The following is a description of a gene set: Comprehensive identification of all functional elements encoded in the human genome is a fundamental need in biomedical research. Here, we present a comparative analysis of the human, mouse, rat and dog genomes to create a systematic catalogue of common regulatory motifs in promoters and 3' untranslated regions (3' UTRs). The promoter analysis yields 174 candidate motifs, including most previously known transcription-factor binding sites and 105 new motifs. The 3'-UTR analysis yields 106 motifs likely to be involved in post-transcriptional regulation. Nearly one-half are associated with microRNAs (miRNAs), leading to the discovery of many new miRNA genes and their likely target genes. Our results suggest that previous estimates of the number of human miRNA genes were low, and that miRNAs regulate at least 20% of human genes. The overall results provide a systematic view of gene regulation in the human, which will be refined as additional mammalian genomes become available. Human Gene Set: MCAATNNNNNGCG_UNKNOWN Genes having at least one occurrence of the highly conserved motif M110 MCAATNNNNNGCG in the regions spanning 4 kb centered on their transcription starting sites. The motif does not match any known transcription factor binding site. from publication Xie X, Lu J, Kulbokas EJ, Golub TR, Mootha V, Lindblad-Toh K, Lander ES, Kellis M (PMID 15735639) studied in species Homo sapiens, and this is the list of marker genes: TAFA1, MAF, RNFT2 (NCBI Gene Id 84900), CNN2, CDCA3 (cell division cycle associated 3), SUV39H1, PTCHD1, SLIT3, HNRNPL, HOXB8, MSX2, AMD1, LONRF3, PAPOLG, HMGN2, OARD1, SH3GL3, NOL6, ATP2A2, POLDIP3, FBXL20, CCNT2, ADAM10, PRADC1, LIG1, VASP, CCT7, FICD, ATF2, JUP, HES1, RAD51C, RMI2, NFYA, NIM1K, ABI1, SPRING1 (NCBI Gene Id 79794), CNNM2, SH3BGRL3 (SH3 domain binding glutamate rich protein like 3), ESRRG, CCNJ, ZFAND5, ACTL6B, PIGA, PPP2R5D, DLX1, CDK19, ATE1, ACTN1, TEX14, WNT1, CYCS, STMN1, NEUROD1, TIAM1, ZNF821, CHD4, MACROD2, ARGLU1, ZIC1, IFRD2, ZSWIM9 (zinc finger SWIM-type containing 9), EPHB1, CDK2AP2, LINC00472, FBXO11, PCDH17, DOLPP1, SQLE, STK35, ZMYND8, NFYC, RAB8A, RNF38, DGCR8, BAHD1, RERE, THAP11, ARL6IP1, SRSF6, CHKA, USP5, TMED2, SORBS1, DCTN2